Given this list of marker genes APOA5, LRPAP1 (LDL receptor related protein associated protein 1), LRP1, ANKRA2 (ankyrin repeat family A member 2), PICALM, PCSK9, APOA1, SACS, CLTC, AP2A1 (adaptor related protein complex 2 subunit alpha 1), APBB3, APP, CLU, AP2M1, APOB, APOE, APBB1, CRP, HSPG2, APOA2, RELN, DAB2, DKK1, LANCL1, HSP90B1, SYT1, LDLRAP1 (low density lipoprotein receptor adaptor protein 1), MESD, SNX17, DNAJA1, APOC3, here is a description of the gene set: studied in species Homo sapiens Binding to a lipoprotein particle receptor. Human Gene Set: GOMF_LIPOPROTEIN_PARTICLE_RECEPTOR_BINDING